The following is a description of a gene set: studied in species Homo sapiens An intracellular signaling cascade that starts with the activation of hippo (STK4/MST1 and STK3/MST2 in mammals and hpo kinase in Drosophila). Hippo then phosphorylates LATS1/2, which in turn phosphoylates the transcriptional co-activator YAP1 (yki in Drosophila), leading to its cytosolic retention and/or degradation. Human Gene Set: GOBP_HIPPO_SIGNALING, and this is the list of marker genes: VCP, TEAD2, YWHAE, SRC, TEAD3, AJUBA, MOB3B, AMOTL1, SIKE1, AMOTL2, MOB1A, WTIP, STRN4, MAPK14 (NCBI Gene Id 1432), WWC1, STK3, NEK8, PPP2CA, MAP2K3, AARS1 (alanyl-tRNA synthetase 1), TEAD1, FAT4, TIAL1 (TIA1 cytotoxic granule associated RNA binding protein like 1, NCBI Gene Id 8430), LATS1, AMOT, YAP1, TEAD4, SHANK2, SAV1, PRP4K, WWC3, STRN3, LIMD1, IQCJ-SCHIP1, NUAK2, SIRT1, MOB4, SLMAP, FRMD6, LATS2, NF2, PPP2R1A, CIT, SCHIP1 (schwannomin interacting protein 1), STRIP1, ARRDC3, VGLL4, WWTR1, DLG5, SOX11, WWC2, STK4, MAP4K4, MARK3, FRMD1, DCHS1, MOB1B, CORO7